Given this list of marker genes FAM13C, FABP5, NKTR, GLCE, TMEM165, CEMIP2, MATN2, IL6ST, KLF2, NDUFA4L2, HIF1A, MIDN (midnolin), PHACTR2, DNAH11, SF1, SH3BP5, LSP1, TUBB2B, STEAP4, DDX17, YBX3, WNT6, STOM, CCDC71L, PNISR, ID3, BCL6, HGF, ZFHX3, GRINA, F2R, CYBRD1, ARGLU1 (NCBI Gene Id 55082), NFE2L2, BHLHE40, RHOBTB3, BTG2, SLC25A37 (NCBI Gene Id 55881), SNORD3A, RSPO4, FN1, LAMC3, FOS, SELENOP, CEBPB, NID1, ITPRIP, GEM, SLC39A14, WEE1, DDIT4, RAMP2-AS1, LPP, JUN, PHYHIP, DACT1, PPP1R15A, CHEK2, BZW1, MIR24-2, PITPNC1, BMP1, MAML2, FBXO32, NR4A2, ETS2, WSB1, ACSL3, SOD2, WNT10A, NUCKS1, FBLN1, PLPP1, ECHDC2 (enoyl-CoA hydratase domain containing 2), DYNC2I1, LDLRAD4, GABRA2, CREB3L2, ETNPPL, FOSL2, BTG3, IDS, ADD3, BCL3, IGFBP4, VEGFA, NTRK3, MIR99AHG, FTL, ELOVL5, MFAP4, SLC35D1, C1RL, C1orf21, EGR1, OTULINL, MAN1A1, MT1A (metallothionein 1A), PLIN2, FHL1, CEP126, RCAN1, here is a description of the gene set: Occular cell types curated from Gautam and Hamashima et al. Multi-species single-cell transcriptomic analysis of ocular compartment regulons from publication Gautam P, Hamashima K, Chen Y, Zeng Y, Makovoz B, Parikh BH, Lee HY, Lau KA, Su X, Wong RCB, Chan WK, Li H, Blenkinsop TA, Loh YH (PMID 34584087) Human Gene Set: GAUTAM_EYE_IRIS_CILIARY_BODY_FIBROBLASTS studied in species Homo sapiens